Given this list of marker genes Krt39, Diaph2, Krt33b, Col5a2, Prkd1, Map7d3, Ilk, Krt90, Ccsap, Cyria, Adamts7, Kctd13, Camp, Tnnt2, Krt84, Add3, Arfgef1, Arpc2, Clip4, Dctn1, Arhgef10, Rhpn2, Arl2, Cdh5, Myo19, Flii, Axin1, Tagln3, Fmn1, Mtpn, Tuba1a, Fbxo5, Myoc, Baiap2, Elmo2, Pfn1, Slc39a12, Rhobtb2, Togaram2, Ripk3 (NCBI Gene Id 76562), Basp1, Trdn, Hdac2, Synpo2, Krt78, Gfap, Mylk3, Ccl21b, Krt76 (NCBI Gene Id 77055), P4ha1, Clip1, F11r, Arpin, Itgb1, Lmod3, Ssh1, Tjp1, Tnfaip1, Ccn2, Ltbp2, Dnm2 (NCBI Gene Id 13430), Edn1, Eps8, Gas2l3, Foxc2, Cit, Shtn1, Loxl2, Rnd3, Pkp2 (plakophilin 2), Lats1, Myoz2, Mad2l2, Antxr2, Rhoh (NCBI Gene Id 74734), Rhpn1, Tmsb15l, Krt17, Map1s, Rac1, Pcm1, Krt83, Tacc2, Iapp, Krt80, Togaram1, Col3a1, Fermt2, Swap70, Kpnb1, Micall2, Ep300, Capza2, Apc, Zfp207, Myl9, Vps33b, Carmil2, Krt7, Bbln (NCBI Gene Id 96985), Ppm1e, Serf1, Coro1c, Tmsb15b2, B4galt7 (beta-1,4-galactosyltransferase 7), Prkar1a, Mlst8, Ccdc66, Bloc1s6, Rhobtb1, Krt16, Pak1, Tpm2, Krt33a, Baiap2l2, Eml2, Tnfaip6, Cap1, Cyfip2, Prph, Dpysl3 (dihydropyrimidinase-like 3), Krt73, Rac3, Actn2, Serpinf2, Kank1, Lmod1, Ssna1, Cd47, Fgf13, Msrb1, Whamm, Mfap5, Krt20, Stmn4, Twf1, Krt10, Hspa1a (NCBI Gene Id 193740), C9orf72, Krt1, Arhgef18 (Rho/Rac guanine nucleotide exchange factor 18), Nlrp5 (NCBI Gene Id 23968), Arhgap12, Hook3, Rnh1, Krt27, Plek, Ssh3, Gm5414, Pecam1, Pik3r1, Usp8, Itgb1bp1, Ghsr, Tnnt1, Mef2a, Bag4, Trpv3, Loxl4, Frmd7, Fer (FER tyrosine kinase), Krt77, Mecp2, Tubb1, Coro6, Pfdn6, Trim54, Anxa2, Apc2, Trf, Ccl21f (NCBI Gene Id 100504346), Ap1ar, Colgalt1, Rflnb, Acan, Cracd, Pcdh15, Ccl21d, Emilin1, Shroom2, Plk3, Tchh, Arhgap35, Aqp2, Arhgap17, 4930544G11Rik, Arhgap25, Crhr2, Arhgef1, Stmn3, Mia3, Krt28, Efemp2, Pik3ca, Nckap1, Brk1, Arhgef5, Rhod, Map3k1, Map2, Col1a1, Wnt4, Mmp11, Cript, Spatc1l, Tpm4, F2rl1, Gmfg, Tgfb3, Col1a2, Arhgap40, Cep126, Bbof1, Bmp10 (bone morphogenetic protein 10), Dapk3, Coro2b, Numa1, Rps3, Rap1gds1, P3h4, Diaph3, Plekhh2, Krt71, Itgb5, Samd14, Synpo, Mybpc2, Kank4, Rhoq, Mybpc3, Katnb1, Ankrd23, Rhoc, Agfg2, Nlrp4f, Bmerb1, Mkks, Prkcq, Nav3, Pacsin1, Arhgef10l, Prex1, Sh3kbp1, Tnnt3, Ttc8, Fchsd1, Clrn1, Cdc42ep5 (NCBI Gene Id 97398), Thsd4, Tubgcp5, Spire1, Krt34, Ccdc88b, Pfdn2, Pls3, Map6d1, Ezr (ezrin), Htt, Adamts19 (ADAM metallopeptidase with thrombospondin type 1 motif 19), Actg1, Klhl41, Spire2, Iqgap1, Tacstd2, Myo1d, Haus2, Marcks, Ccl11, Nkx2-5, Klhl24, Fmn2, Col11a2, Arrb1, Chrna7, Kank3, Arf6, Krt42, Pik3r2, Myo1g, Eml4, Xirp2, Pxn, Dnajb6, Pgm5, Bcl2, Capn1, Cd36, Cav3 (NCBI Gene Id 12391), Dnai3, Nme7, Mapre3, Actr2, Dyrk1a, Grb2, Hsp90ab1, Tpm1, Khdc3, Pfn3, Cstb, Espnl, Tbcb, Krt74, Krt32, Magel2, Fkbp10, Nedd1, Slit2, Rhov, Twf2, Krt2, Shank1, Pdlim3, Krt35, Washc4, Hdac6, Ccl24, Tpm3-rs7, Plod2 (procollagen lysine, 2-oxoglutarate 5-dioxygenase 2), Cyrib, Gmfb, Tubgcp3, Svil (supervillin), Ckap5, Cdc42, Trpv4, Fchsd2, Prkce, Lpar1 (lysophosphatidic acid receptor 1), Fbln5, Mid1, Tln1, Cttn, Cdc42ep1, Capza1b, Nck1, Git1, Spast, Arhgap6, Pfn5, Dstn, Pick1, Fkbp4, Krt36, Ssh2, Katnbl1, Abitram, Alox15, Shroom1, Lmod2, Ccdc13, Enah, Mical3, Iqgap2, Pdxp, Esam (endothelial cell-specific adhesion molecule), Rhou, Vil1, Tpx2, Myo15a, Ripk1, Add1, Crtap, Kif18b, Washc1, Pawr, Sdc4, Capza3, Fhdc1, Cdsn, Map10, Eef2k, Kptn, Arhgap18, Kif19a, Ppfibp1 (PTPRF interacting protein, binding protein 1 (liprin beta 1)), Hax1, Tppp3, Ldlr, Actn1, Arpc1a, Plec, Myoz1, Hsp90b1, Snx9, Cryaa, Wasl, Dsp, Cdc42ep2, Hcls1, Sh3pxd2b, Bbs4, Krt40, Myom2, Sirpa, Optc, Krt85, Nefm, Hook2, Pdgfrb, Aif1l (allograft inflammatory factor 1-like), Eppk1, Kif18a, Gas2l2, Zbed3, Pafah1b1, Myo1c, Apoe, Katna1, Epha1, Rictor, Rb1, Trem2, Coro1a, Camsap1 (calmodulin regulated spectrin-associated protein 1), Mfap4 (microfibrillar-associated protein 4), Rhoj (ras homolog family member J), Lima1, Aebp1, Ccdc88c, Myo1e, Krt5, Sfrp2, Des, Rock2, Cst3, Slain2, Cep192 (NCBI Gene Id 70799), Casp4, Pak3, Mir129-2, Ldb3, Gpr65, Mapk8, Cep120 (NCBI Gene Id 225523), Aurkb, Plod3, Krt19, Myo5c, Ptger4, Rasa1, Dync1h1, Rnd1, Ptk2b, Flnc, Krt25, Dvl1, Gda, Dmtn, Ush1c, Sorbs1, Dreh, Stmn1, Arhgef15, Sh3bp1, Tubg1, Cflar, Washc5, Tardbp, Wasf2, Csrp3, Prkn, Apoa1, Nup153, Ppp1r9a, Map1a, Scx, Tmod2, Pdgfra, Fscn1, Tenm1, Asap3, Elmo3 (engulfment and cell motility 3), Rgs4 (regulator of G-protein signaling 4), Taok1, Nefl, Tpm3, Camsap3, Cryab, Col6a1, Casq2, Braf, Myo6, App, Tcap, Nckap5, Rhof, Wdr73, Acta1, Pof1b, Kif2c, Stmn2, Krt12, Clip2 (NCBI Gene Id 269713), Ndel1, Elmo1, Drg1, Rhog, Bfsp1, Myo1b, Ccl21e, Inpp5j, Prune1, Nox4, Limk2, Washc2, Nckap1l, Krt86, Mef2c (NCBI Gene Id 71350), Abl2, Wnt11, Loxl1, Tmeff2, Gba2, Flna, Ina, Tagln2, Nckap5l, Tle6, Zeb2, Krt15, Prkci, Krt82, Tlr2, Myo1f, Fscn3, Ttc17 (tetratricopeptide repeat domain 17), Tppp2, Shroom4, Hspg2, Rnd2, Bid, Dpt, Clec2i, Comp, Myh11, Myom3, Krt81, Tesk1, Mtor, Zyx, Arpc5, Spag6l, Pfdn5, Cyp1b1, Mtss1, Cyfip1, Rgcc (regulator of cell cycle, NCBI Gene Id 66214), Mybph, B2m, Loxl3, Inpp5k, Cavin4, Rapgef3, Bfsp2, Map4, Nf1, Espn, Prkcd, Met, Bin1, Mybpc1, Ccl26, Ctnna2, Src, Htr1a (NCBI Gene Id 15550), Kiss1r, Fam171a1, Rufy3, Gas7, Aif1, Pycard (NCBI Gene Id 66824), Coro1b, Slain1, Mical2, Gja1, Arfip2, Arpc3, Sptbn1, Tnxb, Smad4, Sorbs3, Ppm1f, Cfl2, Krt6b, Kif21a, Evl, Plekhg2, Six4 (NCBI Gene Id 20474), Cdc42ep4, Csf3, Krt14, Cnn3, Alms1, Tacc3, Hspa1b, Actn4, Lox, Krt23, Arfip1, Cnn2, Ltbp4, Coro7, Ccl21a, Actr3, Tubb4a, Fscn2, Sh3d21, Pfn2, Cdk5rap2, Cobl (NCBI Gene Id 211381), Wipf3, Tmsb10, Shroom3, Kbtbd13, Cd2ap, Abi2, Cdc42ep3, Ift88, Fes, Smn1, Zfp469, Carmil1, Myom1, Arpc1b, Adprhl1, Adamts12, Cotl1, Daam2, Arap1, Limk1, Gsn, Carmil3, Tmsb4x, Capg, Tubgcp4, Ddr2, Myo7a, Trim27 (tripartite motif-containing 27), Cul3, Cenpj, Pfdn1, Ang (angiogenin, ribonuclease, RNase A family, 5), Diaph1, Grem1, Fam107a, Ppfia1 (protein tyrosine phosphatase, receptor type, f polypeptide (PTPRF), interacting protein (liprin), alpha 1), Cdkn2a, Spef1, Pak2, Vasp, Arpc4, Smad3, Rp1, Cav1, Gm28729, Pdlim4, Cib1, Phldb2, Clasp1, Hook1, Krt31, Avil, Myo5a, Lcp1, Vim, Myo1h, Fus, Hip1, Bcar1, Psen1, Myl2, Pfdn4, Akap9, Vill, Ckap2 (NCBI Gene Id 80986), Vipas39, Sptb, Akap13, Col11a1, Fhod1, Inf2, Marcksl1, Scin, Naa80, Nrap, Gm14137, Sptan1, Arhgef7 (Rho guanine nucleotide exchange factor), Krt4, Golga2, Cx3cl1, Pde4dip, Tac1, Tmod1, Wasf3 (NCBI Gene Id 245880), Myh10, Kif2b, Mypn, Krt24, Wasf1, Kank2, Csrp1, Arhgap28, Atp7a, Map1b, Tsc1, Tbcd, Sema5a, S1pr1, Flg, Tacr1, Pcnt, Vbp1, Gas2, Camsap2, Ext1, Id1, Cgnl1, Icam1, Col2a1, Myadm, Ccdc88a, Capza1, Fat1, Cap2, Psrc1, Mid1ip1, Catip (NCBI Gene Id 636180), Myo5b (myosin VB), Nf2, Gdpd2, Ppargc1b, Krt72, Krt8, Ankrd53, Xirp1, Csnk1d, Gm5478, Synpo2l, Pakap, Rhoa (NCBI Gene Id 51787), Wmp, Bax, Hdgfl3, Kash5, Baiap2l1, Selenon, Pls1, Krt13, Srf, Nefh, Krt6a, Dlg1, Ttbk2, Pkp1, Krt75, Foxc1 (NCBI Gene Id 17300), Pdlim1, Tgfbr1, S100a10, Mapre1, Ppp1r9b, Capzb, Krt87, Tmod4, Mzt1, Rdx (NCBI Gene Id 19684), Ooep, Adamts14, Shank3, Atxn7, Was, Tgfb2, Myo7b, Cald1, Hip1r, Rac2, Ghrl, Rflna, Nebl, Spta1, Tubg2, Luzp1, Add2, Serpinh1, Ccdc57 (coiled-coil domain containing 57), Eln, Nde1, Pxdn, Wdr1, Wdr72, Neurl2, Specc1l, Dsg3, Fhod3, Arpc5l, Prox1, Dbn1, Tubgcp6, Tmod3, Kirrel1 (NCBI Gene Id 320339), Actc1 (actin, alpha, cardiac muscle 1), Emp2, Abl1, Chp1, Plod1, Cdkn1b, Ift172, Sgk1, Ttn, Kif24, Csrp2, Kif14, Dbnl, Ermn, Krt9, Wdr47, Myo1a, Clu, Limch1 (NCBI Gene Id 77569), Mdm2, Mfn2, Clip3, Chadl, Slk, Tppp, Col5a1 (collagen, type V, alpha 1), Myh6, Agfg1, Neb, Washc3, Dlc1, Tubgcp2, Rab11a, Fsd1, Adamts2, Myh9, Col14a1, Gas2l1, Hspa8, Arhgef2, Krt26, Capn3, Msrb2, Inppl1 (inositol polyphosphate phosphatase-like 1), Nin, Mtm1 (NCBI Gene Id 56614), Arf1, Lmx1b, Nrp1, Rhob, Cnn1, P3h1, Nck2, Nphs1, Mical1, Clasp2, Mkx, Iqgap3, Krt79, Jmy, Casq1, Ero1a, P4ha3, Phactr1, Limd2, Cfl1, Shh, Mapt, Snca, here is a description of the gene set: species: Mus musculus Mouse Gene Set: GOBP_SUPRAMOLECULAR_FIBER_ORGANIZATION A process that is carried out at the cellular level which results in the assembly, arrangement of constituent parts, or disassembly of a supramolecular fiber, a polymer consisting of an indefinite number of protein or protein complex subunits that have polymerised to form a fiber-shaped structure.